Given this list of marker genes BRAF, HRAS, KRAS, NRAS, SMO, here is a description of the gene set: Nevus sebaceous species: Homo sapiens Human Gene Set: HP_NEVUS_SEBACEOUS A congenital, hairless plaque consisting of overgrown epidermis, sebaceous glands, hair follicles, apocrine glands and connective tissue. They are a variant of epidermal naevi. Sebaceous naevi most often appear on the scalp, but they may also arise on the face, neck or forehead. At birth, a sevaceous nevus typically appears as a solitary, smooth, yellow-orange hairless patch. Sebaceous naevi become more pronounced around adolescence, often appearing bumpy, warty or scaly.